The following is a description of a gene set: CYP1A2 oxidizes a variety of structurally unrelated compounds, including steroids, fatty acids, and xenobiotics. It is most active in catalyzing N-hydroxylation or N-dealkylation reactions. part of: Xenobiotics Reactome Pathway: Aromatic amines can be N-hydroxylated or N-dealkylated by CYP1A2 studied in species Homo sapiens, and this is the list of marker genes: CYP1A2